The following is a description of a gene set: Human Gene Set: GOBP_VESTIBULOCOCHLEAR_NERVE_FORMATION species: Homo sapiens The process that gives rise to the vestibulocochlear nerve. This process pertains to the initial formation of a structure from unspecified parts. This sensory nerve innervates the membranous labyrinth of the inner ear. The vestibular branch innervates the vestibular apparatus that senses head position changes relative to gravity. The auditory branch innervates the cochlear duct, which is connected to the three bony ossicles which transduce sound waves into fluid movement in the cochlea., and this is the list of marker genes: TIFAB, ATP8B1, PAX2, DCANP1, NEUROG1